Given this list of marker genes Phb2, Taco1, Atp7a, Cox17, Sco1, Sphk2, Ndufa4, Coa8, here is a description of the gene set: studied in species Mus musculus Mouse Gene Set: GOBP_REGULATION_OF_CYTOCHROME_C_OXIDASE_ACTIVITY Any process that modulates the frequency, rate or extent of cytochrome-c oxidase activity.